The following is a description of a gene set: Discrimination between self vs. non-self and adequate response to infection and tissue damage are fundamental functions of the immune system. The rapid and global spread of known and emerging viruses is a testament that the timely detection of viral pathogens that reproduce within host cells, presents a formidable challenge to the immune system. To gain access to a proper reproductive niche, many pathogens travel via the host vasculature and therefore become exposed to humoral factors of the innate immune system. Although a cascade of coagulation factors plays a fundamental role in host defense for “living fossils” such as horseshoe crabs (Xiphosurida spp), the role of the coagulation system in activation of innate responses to pathogens in higher organisms remains unclear. When human type C adenovirus (HAdv) enters the circulation, 240 copies of coagulation factor X (FX) bind to the virus particle with picomolar affinity. Here, using molecular dynamics flexible fitting (MDFF) and high resolution cryo-electron microscopy (cryo-EM), we defined the interface between the HAdv5 hexon protein and FX at pseudo-atomic level. Based on this structural data, we introduced a single amino acid substitution, T424A, in the hexon that completely abrogated FX interaction with the virus. In vivo genome-wide transcriptional profiling revealed that FX-binding-ablated virus failed to activate a distinct network of the early response genes, whose expression depends on transcription factor NFKB1. Deconvolution of the signaling network responsible for early gene activation showed that the FX-HAdv complex triggers MyD88/TRIF/TRAF6 signaling upon activation of toll-like receptor 4 (TLR4) that serves as a principal sensor of FX-virus complex in vivo. Our study implicates host factor “decoration” of the virus as a mechanism to trigger innate immune sensor that respond to a misplacement of coagulation FX from the blood into intracellular macrophage compartments upon virus entry into the cell. Our results further the mounting evidence of evolutionary conservation between the coagulation system and innate immunity. Human Gene Set: GSE36078_WT_VS_IL1R_KO_LUNG_DC_AFTER_AD5_INF_UP from publication Doronin K, Flatt JW, Di Paolo NC, Khare R, Kalyuzhniy O, Acchione M, Sumida JP, Ohto U, Shimizu T, Akashi-Takamura S, Miyake K, MacDonald JW, Bammler TK, Beyer RP, Farin FM, Stewart PL, Shayakhmetov DM (PMID 23019612) Genes up-regulated in Lung dendritic cell from Ad5 infection wildtype mice versus Lung dendritic cell from Ad5 inf IL-1R mice. studied in species Homo sapiens, and this is the list of marker genes: NUCB1 (NCBI Gene Id 4924), TM6SF1 (transmembrane 6 superfamily member 1), DUSP9, SAMHD1, CTSW, LGALS3, MYLK2, CLDND2, REEP5, SUN1, IER3, SLBP, KLRK1, PRKAB2, NUDT4, ITGA1, SOCS2, CDKN2C, RCN1, SNAI3, ECH1, AQP4, GALNT3, PRRG4, DGKH, FHL2, NCAPG (non-SMC condensin I complex subunit G), DEPDC1B, CTNNA1, ENTPD1, TXNDC5, USP48, LTK, SH2D3C, PILRB, PYGL, ZYX, SYTL1, MMP23B, HRH4, NFIL3, GZMA, USP20, FCGR2B, MYL4, AQP9, ZEB2, DOCK5, LYST, HID1, SLC8B1, ID2, PPP1R3B, VAX2 (NCBI Gene Id 25806), SYP, SSC5D, CDKN1A, PLEK, IFITM2, YBX3, APOBR, PRICKLE3, SWAP70, DENND5A, LAIR1, NIBAN2, GAS7, FES, NQO2, YES1, FLT3LG, CSF2, MPND, SMC1B, KLRD1, KLRC1, WWP1, SMAD3, PTPRJ, RGS2, NCCRP1, CAMK2N1, CXCR6, KRT32, CERCAM, ATP8B4, GPR68, EFHD2, TAFA3, RPA2, ARHGEF2, BTG2, ACTN2, RBL2, MAP6, CCL5, CHAF1B, MVB12B, RHOJ, ANXA1, ITSN1, BHLHE40, CRIP1, SLC2A3, PLP2, GPC1, SLAMF7, ARHGAP18, ELOVL7, SLC41A2 (NCBI Gene Id 84102), IQGAP2, IQCG, GP6, IL2RB, PPP3CA, SELPLG, GGT1, L1CAM, SMPD1, ITGB7, SGK1, IFITM3, CD7, TMEM37, SLC30A7, S1PR5, MYO1F, ATP8A2, RCBTB2, ADGRG3, MKI67, ANXA6, RASL11A, S100A6, CD47, EXO1, SEPTIN8, PRKX, TYROBP, TNS2, CYP2S1, EHBP1L1, LPIN1 (NCBI Gene Id 23175), NHSL2, F2RL2, P2RY14, PTGIR, EMID1, KCNJ8, HAAO, TKTL1, IL2RA, SLCO3A1 (solute carrier organic anion transporter family member 3A1), CCR5, ERO1A, GNA11, CD46, PRRC1, ERMN, CHRNA9, ZDHHC15, CTSC, CHSY1, METRNL, CAPG, CCR2, TMBIM1, FGD4 (NCBI Gene Id 619403), ITGAX, NKG7, EDARADD, VIM (vimentin), LGALS1, RIPOR3, KLRG1, SPTSSA, SAMSN1, POLE, PDHX, RRM2, RBM47, SERPINE2 (serpin family E member 2), KRT14, CDH1, F2R, IFNGR1, ITGB3, GZMM, C15orf48, RXRA, RNASE4, EIF4E3, CAPN2, PIK3AP1, DUSP5, GZMB, DKKL1, GRAMD2B, CYP3A7, MZF1